Given this list of marker genes Gm6210, Gm9001, Gm22283, Gm5995, Gm44163, 4933439N06Rik, Gm8992, Gm8993, Rnf26rt, Gm44126, Gm23924, Gm8999, Gm44113, here is a description of the gene set: studied in species Mus musculus Mouse Gene Set: chr6C2